The following is a description of a gene set: studied in species Mus musculus Mouse Gene Set: MIR_140_5P from publication Chen Y, Wang X (PMID 31504780) Genes predicted to be targets of miRBase v22 microRNA mmu_miR_140_5p in miRDB v6.0 with MirTarget v4 prediction scores > 80 (high confidence targets)., and this is the list of marker genes: Drd4, Ifit2, Psma3, Abhd5, Hdac4, Ror1, Slc16a6, Galnt16, Stradb, Vps18, Cps1, Klf9, Strn3, Bmp2, Mmd, Dlg2, Tssk2, Msantd5f6, Ptgr2, Wnk2, Vcpip1, Dcun1d3, Wnt9a, Bloc1s2 (NCBI Gene Id 73689), Eif4g2, Entr1, Naf1, Lrp4, Creb3l1, Septin2, Car9, Egr2, Rbbp4, Kctd12b, Kbtbd2, Mpv17, Tgfbr1, Med13, Erc2, Zfp800, Lhfpl2, Wnt11, Epb41l2, Arsk, Pdgfra, Ubr5, Heg1, Rnf19a, Srcap, Cep350, Hs2st1, Hsd17b6, Dlgap1, Dnm3, Fgf9, Eeig1, Npr3, Mfsd14a, Ms4a10, Nucks1, Yes1, Mep1a, Katnbl1, Nog, Tmem204, Igfbp5, Dpysl2, Nlk, Col4a3, Vezf1 (vascular endothelial zinc finger 1), Arhgef40, Phlpp1, Rala, Cbll1, Cdh11, Hdac7 (NCBI Gene Id 56233), Capn1 (NCBI Gene Id 12333), Rfx7, Chac2